The following is a description of a gene set: studied in species Mus musculus from publication Tabula Muris Consortium (PMID 32669714) Mouse Gene Set: TABULA_MURIS_SENIS_LIVER_HEPATOCYTE_AGEING, and this is the list of marker genes: C4b, Macrod1, Prodh2, Swi5, Noct, Apoa1, Nnmt, Aldh4a1 (aldehyde dehydrogenase 4 family, member A1), Apoa5, Asl, Anp32a (acidic nuclear phosphoprotein 32 family member A), Cyp26a1, Coq8a, Cfl1, Gstt3, Car3, Jund, Oaz1, Bhlhe40, Ass1, Pigr, Clu, Tmem176a, Psap, Apol9a, Ahcy (S-adenosylhomocysteine hydrolase), Aldh1l1, Pnrc1, Fdps, Sult2a7, Jun, Cyb5r3, Gnmt, Aqp8, Id3, Got2, Grn, Aldh2, Clec2d, Oat, Hamp, Zap70, Ldha, Cd36, Tle5, Acaa1b, Aldh7a1, F10, H3f3b, Etfb, Adh5, Hamp2, Dcxr, Qdpr (quinoid dihydropteridine reductase), Ttc36, Pltp, Got1, Hpd, H2-D1, Ptms, Fads2, Cth, Sult1a1, Cbs, Cdo1, Col18a1, H2-K1, Sult2a2, Slc25a10, Rpl31-ps12, Bhmt, Apon, Amdhd1, Krt8, Ifi27, Efna1, Selenbp1, Agmat, Serpina3m, Serpinf2, Upb1, Gpt, Sardh, Fah, Actb (NCBI Gene Id 11476), Rsrp1, Tmem254, Afmid (NCBI Gene Id 71562, arylformamidase), Gjb1, Hebp1, Rnf125, Id2, Aldh1b1, Gls2, Lrg1, Ambp, Rdh16f2, Hgfac, Haao, Gamt, Igfbp4, Gcdh (NCBI Gene Id 97486), Srebf1, Tfr2, Mpst, Rps15a-ps4 (NCBI Gene Id 675729), Psen2 (NCBI Gene Id 98295), Krt18, Sult2a1, Tmem176b, Apol9b, Ftcd, Gapdh, H2-Q10, Ly6e, Zfp395, Ctsb, Gas6, Ugt3a1, Ndrg2, Cyp3a44, Qsox1, Scd1, Proc, Agxt, Paqr9, Nherf1, Spr, Serpinb1a, Tmsb4x, Mup2, A1bg, Mup20, Fkbp8, Acads, Fpgs, Actg1, Cebpa